The following is a description of a gene set: species: Homo sapiens from publication Lund R, Aittokallio T, Nevalainen O, Lahesmaa R (PMID 14607935) Human Gene Set: GSE2770_UNTREATED_VS_TGFB_AND_IL12_TREATED_ACT_CD4_TCELL_2H_UP Th1 and Th2 cells arise from a common precursor cell in response to triggering through the TCR and cytokine receptors for IL-12 or IL-4. This leads to activation of complex signaling pathways, which are not known in detail. Disturbances in the balance between type 1 and type 2 responses can lead to certain immune-mediated diseases. Thus, it is important to understand how Th1 and Th2 cells are generated. To clarify the mechanisms as to how IL-12 and IL-4 induce Th1 and Th2 differentiation and how TGF-beta can inhibit this process, we have used oligonucleotide arrays to examine the early polarization of Th1 and Th2 cells in the presence and absence of TGF-beta after 0, 2, 6 and 48 hours of polarization. Genes up-regulated in CD4 T cells: untreated (0h) versus activated by anti-CD3 and anti-CD28 and then stimulated by TGFB1 and IL-12 (2h)., and this is the list of marker genes: GRIA4, PFN2, SLC13A1, WASF2, STT3A, TMPRSS11F, RCL1, SLC22A1, LYL1, CCDC40, ID2, COL6A2, ADAMTS9, KRT27, RGS16, NUMA1, CAGE1, CHAD, C8orf48, ERAS, TRHR, SLC22A12, PLSCR4, PTBP1, IL12RB2, MAN2A2 (mannosidase alpha class 2A member 2), GGT5, B4GALNT2, DMRT3, CBLC, UQCC5, LINC00511, ABCA6, CSN3, C16orf54, ABI3, CRMP1, ARMC5, GJA10, CLEC2L, ATP6V0D2, ACOX1, ZNF280B, CPSF4, SLC2A6, STEAP1, PTPRG, MROH2B (maestro heat like repeat family member 2B), EGR2, ABCA12, ATG7, TAP1, RPL18A, RPLP2, CYSRT1, GTF3C5, NXPH2, GPR12, PRDM16, EZH2, LLGL1, STIM1, SCML4, ZNF143, LSM11, NUDT16, KDM5D, CDK3, TP73, UQCC2, ACTN1, KDF1, SLC5A7, ZIC4, TPRG1L, RPS6KL1, CASR, ZNF521, FOXH1, BPIFA3, IP6K2, C11orf71, THRAP3, CCDC107, SMG8, MRPL11, FAM120AOS, ARF3, MC2R, WNT2, RASSF7, COL26A1, IL27RA, GABRB1, GRIPAP1 (NCBI Gene Id 84538), CBLN2, THBD, LRRC1, SLC27A1, POLR1C, ADRM1, XRCC1, TMLHE, TSSK4, LPP-AS2, AFAP1L1, POU1F1, HCRTR1, VAMP5, SFT2D2, IFITM5, KCNK4, GALNS, RIMBP2, CDK20, TGM4, GABRB2, ANKLE2, ADGRL4, TMEM158, ALDH3A1, NDUFA11, TRABD, CLXN, WWC1, YPEL2, CLIC6, ZFPM2, SEMA3F (semaphorin 3F), SLC12A8, HACD3, APRT, METAP2, SEMA6C, HAO2, TMT1B, SBSN, SSH3, AFF3, JUND, COA3, IGSF21, EPHB6, MLH3, LTBR, PIGZ, PRKAB1, SNTA1 (syntrophin alpha 1), APLP1, GSTCD, PRR15L, RPL31, LAG3, SEBOX, VKORC1L1, SAYSD1, CAPSL, CCNE1, LRRIQ4, UQCC3, HADHA, PTPRS, TRIM9, DHTKD1, HS1BP3, HADH, ANG, IGSF1 (immunoglobulin superfamily member 1), DUOXA1, BFSP1, XRCC3, PTHLH, TELO2, TBCEL, CCDC28B, TXN, PLA2R1, SLC28A3, DDR2, MYOG, KDM3B, NPTX1, ANO3, HEXB, FUNDC2, HBZ, CBFA2T2, TRIM28, CSDC2, CSMD3 (CUB and Sushi multiple domains 3), KRT7, MTMR11, LAMTOR1, SASH3, CCDC28A, IGSF9B, OSBP2, UPK3BL1, OPRM1, MAPK8IP2